Given this list of marker genes ANKRD22, IRF7, GBP1, SP110, RPS6KC1, CD74, KARS1, DDX60, RSAD2, MX1, RIPK2 (NCBI Gene Id 8767), JAK2, FZD2, IFI35, TRIM5, CASP4, SLC6A12, APOL3, CASP5, OAS3, LPGAT1, PTPRO, BLVRA, TDRD7, LMO2, OASL, IFI44, XAF1, IFI30, TOR1A (NCBI Gene Id 1861), PSMB9, SCO2, P2RY14, SCARB2, IL1RN, NCOA7, GAS6, TRIM6, RIGI, TMEM123, CEACAM1, ZBP1, SCIMP, IFI44L, ZC3HAV1, FGL2, STX11, ATF3, IFIH1, OAS2, MYOF, RGL1, GCH1, PANK2, ZNF684, FRMD3, STAT2, ISG15, TRAFD1, EIF2AK2 (NCBI Gene Id 5610), PSME1, MX2, CMPK2, CREG1, LYSMD2 (NCBI Gene Id 256586), FAM225A, CD300A, LY6E (lymphocyte antigen 6 family member E), TNFSF13B, TYMP (NCBI Gene Id 4334), TMEM208, IFI6, CUL1, IFI16, PHF11, SP140, RPAP3, C3AR1 (NCBI Gene Id 719), DRAP1, LAMP3, PLSCR1, GBP2 (NCBI Gene Id 2634), IFIT3, UNC93B1, ACOT9, MT2A, PARP12, IL15, EPSTI1, GBP4, TRIM56, PARP9, IFIT1, OAS1, GBP5, CTSL, ZNFX1, CCR1, FBXO6 (F-box protein 6), BATF2, SAMD4A, LAP3, DYNLT1, MOV10, MLKL, UBE2L6, FCER1G, PPCDC, WARS1, IFITM1, OTOF, C1GALT1C1, CASP1, HERC6, ISG20, TAP1, ATF5, TRIM22, SAT1, TCN2, LHFPL2, TLR7, DHX58, PARP14, SBNO2, HELZ2, STAT1, PARP10, AIM2, here is a description of the gene set: from publication Franco LM, Bucasas KL, Wells JM, Niño D, Wang X, Zapata GE, Arden N, Renwick A, Yu P, Quarles JM, Bray MS, Couch RB, Belmont JW, Shaw CA (PMID 23878721) Identification of the host genetic factors that contribute to variation in vaccine responsiveness may uncover important mechanisms affecting vaccine efficacy. We carried out an integrative, longitudinal study combining genetic, transcriptional, and immunologic data in humans given seasonal influenza vaccine. We identified genes exhibiting a transcriptional response to vaccination, significant genotype effects on gene expression, and correlation between the transcriptional and antibody responses. The results show that variation at the level of genes involved in membrane trafficking and antigen processing significantly influences the human response to influenza vaccination. More broadly, we demonstrate that an integrative study design is an efficient alternative to existing methods for the identification of genes involved in complex traits. DOI:http://dx.doi.org/10.7554/eLife.00299.001. Genes positively correlated with antibody response in blood in adults (18-40) after exposure to Sanofi Pasteur, SA, Inactivated influenza vaccine, time point 1D species: Homo sapiens Human Gene Set: FRANCO_BLOOD_SANOFI_PASTEUR_SA_INACTIVATED_INFLUENZA_VACCINE_CORRELATED_WITH_ANTIBODY_RESPONSE_AGE_18_40YO_1DY_POSITIVE